Given this list of marker genes FIBIN, CCN1, PPP1R14A, MYH10, BMP5, LUM, RARRES2, A2M, INMT, FOS, SPINT2, LIMCH1, RGCC, MFAP4, LTBP2, GPC3, CFD, USP53, FHL1, DST, FGFR4 (fibroblast growth factor receptor 4), SRGN, PTGDS, LBH, SELENOP, SLIT2, CDH11, SCN7A, ELN, PLEKHH2, TIMP3, C7, CES1, TCF21, ITGA8, MAMDC2, CCN2, FBLN5, MACF1, GPM6B, TGM2, G0S2, PLPP3, FN1, AOC3, ADH1B, FMO2, VEGFD, TMT1A, here is a description of the gene set: from publication Gavish A, Tyler M, Greenwald AC, Hoefflin R, Simkin D, Tschernichovsky R, Galili Darnell N, Somech E, Barbolin C, Antman T, Kovarsky D, Barrett T, Gonzalez Castro LN, Halder D, Chanoch-Myers R, Laffy J, Mints M, Wider A, Tal R, Spitzer A, Hara T, Raitses-Gurevich M, Stossel C, Golan T, Tirosh A, Suvà ML, Puram SV, Tirosh I (PMID 37258682) Human Gene Set: GAVISH_3CA_METAPROGRAM_FIBROBLASTS_CAF_3 In this study, an extensive analysis was conducted to define meta-programs (MPs) capturing intra-tumor heterogeneity across a spectrum of tumor types. The approach utilized non-negative matrix factorization (NMF) to analyze each cell type separately within individual tumor samples. This involved the analysis of malignant cells, macrophages, fibroblasts, endothelial cells, epithelial cells, T-cells, and B-cells. NMF was executed with varying parameter values (K=4, 5, 6, 7, 8, 9), thereby generating 39 programs for each cell type per sample. Each NMF program was summarized by the top genes based on NMF coefficients.\nRobust MPs were then delineated for each cell type using a set of stringent criteria, including recurrence within the same tumor, similarity to programs in other tumors, and non-redundancy within a tumor. Subsequently, these robust NMF programs were clustered (per cell type) based on Jaccard similarity, leading to the identification of MPs associated with each cell type.\nTo enhance the quality of the MPs, a refinement steps were undertaken, involving the removal of MPs suspected of reflecting low-quality data (with an overrepresentation of ribosomal proteins or mitochondrial-encoded genes), single-study inclusion, or similarity to miss-annotated cell types. Genes upregulated in subsets of cells of a given type within various tumors studied in species Homo sapiens